Given this list of marker genes FGF16, FGF5, FGF1 (fibroblast growth factor 1), FGF7, FGFR2, FGF10 (fibroblast growth factor 10), FGF17, FGF2, FGF6, FGF22, FGF18, FGF8, FGF9, FGF23, FGFBP3, FGF3, FGF20, FGFBP1, FGFBP2, FGF4, here is a description of the gene set: Human Gene Set: REACTOME_FGFR2_LIGAND_BINDING_AND_ACTIVATION FGFR2 ligand binding and activation studied in species Homo sapiens